The following is a description of a gene set: The chemical reactions and pathways resulting in the breakdown of purine deoxyribonucleotide, a compound consisting of deoxyribonucleoside (a purine base linked to a deoxyribose sugar) esterified with a phosphate group at either the 3' or 5'-hydroxyl group of the sugar. Human Gene Set: GOBP_PURINE_DEOXYRIBONUCLEOTIDE_CATABOLIC_PROCESS species: Homo sapiens, and this is the list of marker genes: NT5C, NT5C1A, PNP, NUDT16, SAMHD1, DNPH1, NUDT18, NUDT15, ADA (NCBI Gene Id 100), NT5C2, XDH, GDA